Given this list of marker genes Hook2 (NCBI Gene Id 319853), Hook1, Dctn1, Tubgcp4, Katnbl1, Kif19a, Pcm1, Slk (NCBI Gene Id 50513), Cib1, Kpnb1, Stmn3, Apc, Clip2 (CAP-GLY domain containing linker protein 2), Tubgcp5, Dlg1, Ezr, Tubgcp6, Trpv4, Tubg2 (NCBI Gene Id 79197), Tubg1, Ccdc88b, Kif21a, Clasp1, Dync1h1, Cep120, Tacc2, Limk2, Cav3 (NCBI Gene Id 12391), Camsap2, Cript (cysteine-rich PDZ-binding protein), Tubgcp2, Cep126, Clip1, Katna1, Rab11a, Map10, Hook3, Tln1, Clip3, Ccdc13, Ift172, Dvl1, Rhoa, Fsd1, Tppp, Wdr73, Pde4dip, Numa1, Ift88, Chp1, Tbcb, Ppfibp1, Plk3, Tacc3, Slain2, Camsap1, Axin1, Camsap3, Slain1, Ccdc88a, Trdn, Tubgcp3, Pafah1b1, Clip4, Ccdc88c, Cenpj, here is a description of the gene set: species: Mus musculus Mouse Gene Set: GOBP_CYTOPLASMIC_MICROTUBULE_ORGANIZATION A process that is carried out at the cellular level which results in the assembly, arrangement of constituent parts, or disassembly of structures formed of microtubules and associated proteins in the cytoplasm of a cell.